Given this list of marker genes FRG1, TSPAN12, DNAJC30, NDP, ZNF408, STN1, MT-ND4L, MT-CO1, LRP5, PCNA, SMAD4, MT-CO3, NDUFS2, MT-ND5, ENG, MT-CYB, SETD2, CTNNB1, MT-ND1, MT-ATP6, MT-ND2, CTC1, GDF2, MT-ND6, MT-ND4, FZD4, ACVRL1, here is a description of the gene set: Human Gene Set: HP_RETINAL_TELANGIECTASIA Retinal telangiectasia Dilatation of small blood vessels of the retina. species: Homo sapiens